The following is a description of a gene set: The aggregation, arrangement and bonding together of proteins and lipids to form a protein-lipid complex. species: Mus musculus Mouse Gene Set: GOBP_PROTEIN_LIPID_COMPLEX_ASSEMBLY, and this is the list of marker genes: Apoa2, Cideb, Lcat, Apoe, Soat2, Mfsd2a, Abca7, Dgat1, Ces1g, Apoa4, Pcdhga3, Soat1, Ces1d, Lpcat3, Fech (NCBI Gene Id 14151), Nr1h2, Sh3gl2, Apoa1, Acsl3, Abca1, Apom, Mttp, Plagl2, Snx9, Bin1, Arf1